Given this list of marker genes GNB1, MTOR, SRC, RPS6, EGR1, PAX8 (paired box 8), PDE4D, PLD1, E2F1, CDKN1B, TSHB, MAP2K3, HRAS, SCRIB, MYL12B, GNAI1, MYC, CCNE1, RALGDS, MAP2K6, PIK3R1, JUN, ADCY3, IGF1R, FOS, RPS6KA1, GNA12, RAP1GAP, PDPK1, CGA (NCBI Gene Id 1081), JAK2, MAPK3, RAP1A, RB1, KCNIP3, GNG2, RAP1B, RAF1, ADCY2, RBL2, GNAI2, GNAO1, BRAF (B-Raf proto-oncogene, serine/threonine kinase), CCND3, AKT1, GNAS, JAK1, MAP2K1, GNAQ, RPS6KB1, MAPK14, APEX1, PLCB1, MAPK1, STAT1, PIK3R2, GNA13, GNAI3, PIK3CA, CDK4, TSHR, TTF1, CREB1, STAT3, CDK2, TTF2, here is a description of the gene set: Thyroid stimulating hormone (TSH) signaling studied in species Homo sapiens Human Gene Set: WP_THYROID_STIMULATING_HORMONE_TSH_SIGNALING